Given this list of marker genes EGFR, PIGL, RS1, GRIN2A, FBXO46, ZNF345, TMEM222, TRIQK, FCRLA, PPP6C, KCNC4, RAD51B, SLC25A23, RCC2, LINC03042, DHX8, ARRB1, HTR3D, IFFO2 (intermediate filament family orphan 2), B3GALT5, HTR3C, IQGAP3, NRXN2, AAK1, AK7, DLK1, SLC13A5, SLC48A1, AGK, CSAG1, CPNE5, CFL1, ARL17A, PAFAH1B2, POLR3C, DLL3, MAP1A, PRAF2, GREM1, SETD9, CLIP3, CRACD, MCCD1, GRM6, ZNF774, ASAH2B, TMCC3, CSAG3, GUCD1, CPNE3, WWTR1, AGAP1 (ArfGAP with GTPase domain, ankyrin repeat and PH domain 1), GTDC1, CHD6 (chromodomain helicase DNA binding protein 6), PPP1R9B, RNF2 (ring finger protein 2), ACSM2A, CCT8L2, HECW1, DNAJC8, NUDT4, MUC17, GFAP, ZNF579, FABP2, MINAR1, GPR82, LCE2C, ZFHX2, ITPRIPL2, FCER2, ITPKC, UBE2W, MROH6, SRGN, DNAJB4, COL11A2, PATZ1 (NCBI Gene Id 23598), MDM4, RNASEH2C, CC2D1A, MEF2D, KSR2, here is a description of the gene set: Genes predicted to be targets of miRBase v22 microRNA hsa-miR-6737-5p in miRDB v6.0 with MirTarget v4 prediction scores > 80 (high confidence targets). from publication Chen Y, Wang X (PMID 31504780) species: Homo sapiens Human Gene Set: MIR6737_5P